The following is a description of a gene set: studied in species Mus musculus Mouse Gene Set: MIR_696 Genes predicted to be targets of miRBase v22 microRNA mmu_miR_696 in miRDB v6.0 with MirTarget v4 prediction scores > 80 (high confidence targets). from publication Chen Y, Wang X (PMID 31504780), and this is the list of marker genes: Fli1, Slc46a3, Parpbp, Slc37a3, Rad50, Prr18, Fbxw11, Ddx3x, Ncam1, Bend3